The following is a description of a gene set: from publication Chen Y, Wang X (PMID 31504780) Human Gene Set: MIR624_3P species: Homo sapiens Genes predicted to be targets of miRBase v22 microRNA hsa-miR-624-3p in miRDB v6.0 with MirTarget v4 prediction scores > 80 (high confidence targets)., and this is the list of marker genes: SP100, IFNAR1, DCUN1D3, ADAM10, AAK1, PFN2, SIM2, PMPCB, SALL1, TNS3, RRAS2, APAF1, PGP, UQCC1, ARAP2, TRAFD1, RNF217, LRP6, GSK3B, ECM2, PUM2, EMC3, KDSR, CD84, CXCL9, ATXN1, SYNE1, OGN, PLEKHA7, NFIB, GNA14, GAS2L3, ITSN1, DOP1B, FST, KIF23, ZDHHC21, CCDC88A, JAG2, ERCC6L2, MAP3K4, TGDS, KDM4C, OTUD7B, POGLUT3, CBX5, WDR7, ADNP, PPP6R3, OPRM1, ACTG1, GNAI1, MCC, FNBP1, DZIP3, CADPS2, KMT5B, GPC6, USP6, CACNA1A, XPO7, CEP290, STARD5, ZNF616, NBEA, PTBP1, ARID4B, KMO, KLF4, RSRC2, PRDM12, SIPA1L2, TUT4, ADPRH, ING5, FBXO45, PMEPA1, EPHB4, TRIAP1, EPC2, HYCC2, PRR32, ULBP1, PCLO, DUSP10, MARF1, GABRB2, DIRAS3, SMAD2, USP32, SATB1, NEGR1, STXBP1, DPP6, ZNF28, SELENOI, CREBRF, CHAMP1